Given this list of marker genes Htr6, Drd4, Htr1d, Htr5b, Gnat2, Vipr1, Galr3, Htr2a, Drd1, Chrm2, Hrh2, Htr1f, Agtr2, Nos2, Htr5a, Htr2c, Fzd2, Htr1a, Htr1b, Chrm5, Anxa1, Gnat1, Chrm4, Htr2b, Gkap1, Chrm1, Hrh3, Hrh1, Htr7 (NCBI Gene Id 15566), Htr4, Hrh4, Pth1r, Or10j5 (NCBI Gene Id 258260), Chrm3, here is a description of the gene set: studied in species Mus musculus Mouse Gene Set: GOBP_G_PROTEIN_COUPLED_RECEPTOR_SIGNALING_PATHWAY_COUPLED_TO_CYCLIC_NUCLEOTIDE_SECOND_MESSENGER A G protein-coupled receptor signaling pathway in which the signal is transmitted via the activation or inhibition of a nucleotide cyclase activity and a subsequent change in the concentration of a cyclic nucleotide.